The following is a description of a gene set: Impaired myocardial contractility species: Homo sapiens Human Gene Set: HP_IMPAIRED_MYOCARDIAL_CONTRACTILITY, and this is the list of marker genes: SCN4A, DSP, JUP, GABRA3, CACNA1S, ABCC9, ALPK3, CSRP3, KCNJ18, KCNE3